The following is a description of a gene set: Hepatoblastoma, the most common pediatric liver cancer, is tightly linked to excessive Wnt/beta-catenin signaling. Here, we used microarray analysis to identify two tumor subclasses resembling distinct phases of liver development and a discriminating 16-gene signature. beta-catenin activated different transcriptional programs in the two tumor types, with distinctive expression of hepatic stem/progenitor markers in immature tumors. This highly proliferating subclass was typified by gains of chromosomes 8q and 2p and upregulated Myc signaling. Myc-induced hepatoblastoma-like tumors in mice strikingly resembled the human immature subtype, and Myc downregulation in hepatoblastoma cells impaired tumorigenesis in vivo. Remarkably, the 16-gene signature discriminated invasive and metastatic hepatoblastomas and predicted prognosis with high accuracy. Genes down-regulated at early fetal liver stage (embryonic days E11.5 - E12.5) compared to the late fetal liver stage (embryonic days E14.5 - E16.5). Human Gene Set: CAIRO_LIVER_DEVELOPMENT_DN from publication Cairo S, Armengol C, De Reyniès A, Wei Y, Thomas E, Renard CA, Goga A, Balakrishnan A, Semeraro M, Gresh L, Pontoglio M, Strick-Marchand H, Levillayer F, Nouet Y, Rickman D, Gauthier F, Branchereau S, Brugières L, Laithier V, Bouvier R, Boman F, Basso G, Michiels JF, Hofman P, Arbez-Gindre F, Jouan H, Rousselet-Chapeau MC, Berrebi D, Marcellin L, Plenat F, Zachar D, Joubert M, Selves J, Pasquier D, Bioulac-Sage P, Grotzer M, Childs M, Fabre M, Buendia MA (PMID 19061838) species: Mus musculus, and this is the list of marker genes: C9, C3, PLA1A, OPRM1, TNFRSF11A, JAK2, ALDH1L1, GM2A, APOB, PLAC8, HGFAC, SLC39A4, DHCR24, TAPBP, ZNF76 (zinc finger protein 76), AHSG, NABP1, DHRS7, GLDC, KLKB1, HMOX1, SEMA4G, F11, AGT, ANGPTL3, CFH, NID1, PHYH, IL1RN, MTARC1, APOF, GSTM3, PRG2, C5, CLDN1, MST1, ALOX5AP, PKN2, HLA-DQA2, FMO1, MAOB, ABCA8, ITIH3, H6PD, PROC, GCAT, ECH1, GRIK5, ST6GAL1, EBP, ADGRE1, DPYS, SERPINF2, CPB2, LCN2, PGM1, DCXR, CBS, LYZ, CYLD, CYBB, FRYL, S100A9, AQP9, SSTR2, BICRAL, NGLY1, TST, OVOL1, SMPDL3A, ACAA2, MAN2A1, STAB2, ACSL1, CROT, NRN1 (NCBI Gene Id 51299), B3GNT3, MPO, PPARA, BDH1, GSN, COL18A1, SLC2A4, CPQ, KNTC1, SPAG5, KIF13B, SLC37A4, PDIA5, APOE, CYP2F1, GRIK1, GSTT2, ALDH3A2, CTSH, OLFM4, ALDH1B1, ARG1, CYP27A1, PGLYRP1, FGG, LYST, FKBP11, HAGH, FGB, C8G, GAMT, SERPINC1, NCAPH2, BHMT, CRP, SQOR (NCBI Gene Id 58472), ABCA7, CD3G, LGALS9, GC, PLG, CPS1 (NCBI Gene Id 1373), HLA-B, LCP1, HAAO, LPIN2, SLC44A4, LCAT, PCYT2, SELENBP1, SERPIND1, LBP, ORAI3, PDE8A, GSTT1, CA5A, C8A, HMGCS1, HMGCS2, LIPC, VTN, PINK1, GCDH, TTPA, ACADM, ANXA1, CTNS, HP, TFR2, LTF, NDRG1, F2, FGA, DDX27, KDELR3, F12, CFP, SLC7A7, RBM14, LRP1, UPK1B, SLC27A5, PON3, NSDHL, GNMT, IGFBP1, ITIH4, ELANE, PCSK7, GPLD1, C1QA, QPRT, CD68, GJB1, AFM, FAH, ITIH1, TAC3, RAD52, AQP1, CLPX, TACC1, SLC16A2, ISG20, ITIH2, KNG1, ABCC6, S100A8, SAA4, HERC1, PYGL, A2M, CES1, CAMP, BRCA1, ENTPD5, PSAP, CSAD, CD302, ASGR2 (NCBI Gene Id 433), MARCHF5, F10, SERPINA10, SERPINF1, TMEM30B, TMPRSS2, HSD17B2, RDH5, SERPINA1, CCR2, SP4, SLC30A9, SPP2, MORC4, SLC38A3, HPN, SERPING1, PRTN3, RIDA, FN1, AMBP, TENT5A, GSTM5, AMY2B, CDH1, MATN2, ETFA, PIPOX, PCK2